The following is a description of a gene set: A receptor-mediated endocytosis process that results in the movement of receptors from the plasma membrane to the inside of the cell. The process begins when cell surface receptors are monoubiquitinated following ligand-induced activation. Receptors are subsequently taken up into endocytic vesicles from where they are either targeted to the lysosome or vacuole for degradation or recycled back to the plasma membrane. species: Mus musculus Mouse Gene Set: GOBP_RECEPTOR_INTERNALIZATION, and this is the list of marker genes: Angpt1, Mdm2, Ap2b1, Drd3, Apln, Ap3m1, Rspo1 (R-spondin 1), Usp46, Mkln1, Sfrp4, Ralb, Arf1, Drd4, Nsf, Adm, Drd2 (NCBI Gene Id 13489), Ahi1, Rnf220, Anxa2, Dnm3, Grk3, Plk2, Sh3gl2, Snx1, Ap2m1, Ramp1, Aplnr, Lpar1, Arrb1, Nrg1, Entrep1, Rin3, Dnm1, Eps15, Ankrd13a (NCBI Gene Id 68420), Itgb1, Ubqln2, Ldlrap1, Fmr1, Sag, Rab31, Tfrc, Syt17, Napb, Myo6, Syk (spleen tyrosine kinase), Rab11fip5, Ceacam1, Lilrb4a, Cd63, Akap5, Rnf216, Gsg1l, Ackr3, Ramp2, Insr, Dnm2, Hamp2, Numb, Cav1, Ap2a2, Caly, Atad1, Magi2, Ptger3, Rab5a, Tbc1d5, Ceacam2, Ramp3, Wnt3a, Cltc, Pard3, Sele, Hap1, Arc, Mtmr2, Ulk1, Apela, Ache, Lilrb4b, Ezr, Cxcr2, Tamalin, Dtnbp1, Rala, Sirt2, Cd9, Ptpn5, Flot1, Itgb2 (NCBI Gene Id 16414), Vac14, Pacsin1, Vegfa, Gria2, Pip5k1c, Efnb2, Ap2s1, Pld2, Wdr54, Hpca, Picalm, Lrp1, Grb2, Dlg4, Cntn2, Cblb, Itch, Iqsec1 (IQ motif and Sec7 domain 1), Grem1, Plcg2, Ins2, Ghr, Dab2, Atxn2, Synj1, Ntf3, Grk4, Cxcr1, Cav3, Dkk1, Rabep1, Calcrl, Lrrtm2, Hamp, Lmbrd1, Itgb3, Scyl2, Cd81, Sh3glb2 (SH3-domain GRB2-like endophilin B2), Nedd4l, Ap2a1, Hgs, Ankrd13b, Grk2 (G protein-coupled receptor kinase 2), Nedd4, Hip1 (NCBI Gene Id 77099), Ankrd13d, Synj2bp, Cd36, Snca, App, Mx2, Lrrtm1, Necab2, Arr3, Ncdn, Ppp3r1, Sdcbp, Susd4, Egf, Tspan7, Pcsk9, Lrpap1 (low density lipoprotein receptor-related protein associated protein 1), Fcer1g (Fc receptor, IgE, high affinity I, gamma polypeptide), Ophn1, Gria1, Scrib, Ins1, Arrb2, Arap1, Pick1